Given this list of marker genes MC4R, SPP1, TNFRSF11A, FSHB, PRKCA, RUFY4 (RUN and FYVE domain containing 4), LTBP3 (NCBI Gene Id 4054), ITGB3, DCSTAMP, DEF8, SYK (NCBI Gene Id 6850), TNFSF11, TMEM64, ADAM8, PLEKHM1, here is a description of the gene set: Human Gene Set: GOBP_POSITIVE_REGULATION_OF_BONE_RESORPTION studied in species Homo sapiens Any process that activates or increases the frequency, rate or extent of bone resorption.